The following is a description of a gene set: studied in species Homo sapiens from publication Luckey CJ, Bhattacharya D, Goldrath AW, Weissman IL, Benoist C, Mathis D (PMID 16492737) The only cells of the hematopoietic system that undergo self-renewal for the lifetime of the organism are long-term hematopoietic stem cells and memory T and B cells. To determine whether there is a shared transcriptional program among these self-renewing populations, we first compared the gene-expression profiles of naïve, effector and memory CD8(+) T cells with those of long-term hematopoietic stem cells, short-term hematopoietic stem cells, and lineage-committed progenitors. Transcripts augmented in memory CD8(+) T cells relative to naïve and effector T cells were selectively enriched in long-term hematopoietic stem cells and were progressively lost in their short-term and lineage-committed counterparts. Furthermore, transcripts selectively decreased in memory CD8(+) T cells were selectively down-regulated in long-term hematopoietic stem cells and progressively increased with differentiation. To confirm that this pattern was a general property of immunologic memory, we turned to independently generated gene expression profiles of memory, naïve, germinal center, and plasma B cells. Once again, memory-enriched and -depleted transcripts were also appropriately augmented and diminished in long-term hematopoietic stem cells, and their expression correlated with progressive loss of self-renewal function. Thus, there appears to be a common signature of both up- and down-regulated transcripts shared between memory T cells, memory B cells, and long-term hematopoietic stem cells. This signature was not consistently enriched in neural or embryonic stem cell populations and, therefore, appears to be restricted to the hematopoeitic system. These observations provide evidence that the shared phenotype of self-renewal in the hematopoietic system is linked at the molecular level. Human Gene Set: GOLDRATH_EFF_VS_MEMORY_CD8_TCELL_DN Genes down-regulated in comparison of effector CD8 T cells versus memory CD8 T cells., and this is the list of marker genes: PAQR7, SIX6, HSF1, TK2, DDX51, KLF17 (NCBI Gene Id 128209), LYSMD1, TAF1A, RERE, RABAC1, SH3BP5, ACP6 (acid phosphatase 6, lysophosphatidic), ZFP90, NEDD4, ABHD14A, CIPC, NSG2, DBNDD2, RASSF5, ARL4C, TRAF5, RGS10, PPP1R14B, KCNJ8, ZBTB20, DDIT3, ZNF692, EIF2AK4, ITM2C, EOMES, ANKRD10, SURF2, IFITM10, PPOX, PISD, CD96, NEDD4L, ABCA2, SLC11A2, ACADM, TNIP1, SESN1 (NCBI Gene Id 27244), ZNF274, TTC14, JUN, RNASE4, TSR1, ZKSCAN3, EZH1, RIMOC1, DBP, ELP3, QDPR, ICE1, CYP4V2, SEMA4B, IL6R, SIPA1L2, RFLNB, TCF7, TESK1, MLYCD, MBP, TSEN34, DALRD3, TLK2, PRKACB, YPEL3, ACP5, RPL39, SUPT6H, NECAP1 (NCBI Gene Id 25977), PHLDB1, CST7, RPL14, PDRG1, RPS23, GMIP, SIT1, BRD3, RPP14, CCND2, PSME2, MAN2C1, SELL, GSTK1, RTTN, STAT4, TRAF1 (TNF receptor associated factor 1), GNL2, SUSD6, CANT1, NCKAP1, BCKDHB, IL4R, DIAPH2, TXK, MFNG, CHCHD7, NACC2, SHISA5, DNAAF10, CD7, SLTM, VKORC1, WDR13, KLF2, WDR75, HSD17B8, PDK1, USP18, LTB, PURA, RPS16, BCL2L11, RTKN, CRLF3, RPS8, ITPR2, TMC6 (transmembrane channel like 6), CCR7, LYSMD2, PLEKHA5, BCL2, SBDS, TTC27, C6orf136, NOTCH4, CTSW, MRPL23, POLR1B, COX7A2L, PLEKHA1, GBE1, DPH5, RASA4, ENTREP3, FAM8A1, XPC, TRAF3IP2, TTC3, ADAM22, SNRK, MTFR1L, IAPP, TDRP, EML5, PRMT3, RAD52, DUSP12, PTPN22, HSD17B11, METTL3, EVL, ADGRG3, AKAP9, RRP1B, TMED4, TRMT1, ADCY7, C12orf57, ASH1L, MECP2, ABCC5, RPLP0, GTF2I, ZFP1, UBLCP1, EMB, SIAH1, ZEB1, POLR3A, TAF1C, XRCC5, COQ9, PDGFB, RPS7, PRSS12, B3GALT6, SLC12A7, SPICE1, H2AJ, EPS15L1, IL7R, CA12, RPS19, LAMP1, SETD4, IL6ST, CCNL2, WDR43, RPS18, DGKA, MCOLN2, MAP4K3, RPLP1, GALNT11, SLC26A2, RPL19, NDUFA7